Given this list of marker genes SYK, FYN, FLT3LG, LCK, FLT3, HCK, here is a description of the gene set: studied in species Homo sapiens Human Gene Set: REACTOME_FLT3_SIGNALING_THROUGH_SRC_FAMILY_KINASES FLT3 signaling through SRC family kinases